Given this list of marker genes Ift70a1 (NCBI Gene Id 78802), Tuba1b, Tuba4a (tubulin, alpha 4A), Dync2i1, Tubb4b, Cluap1, Ift57, Dynlt5, Kifap3, Ift81, Wdr35, Ift25, Dynlrb2, Dync2i2, Ift80, Ift88, Tuba1c, Tubb4a, Dynlt2a3, Dynll1, Tuba3b, Ift172, Ift70b, Tubb6, Ift27, Tuba1a, Ift74, Tubb2b, Dynlt2a2, Ift22, Ttc21b, Kif3c, here is a description of the gene set: part of: Assembly of the 9+0 primary cilium This event has been computationally inferred from an event that has been demonstrated in another species.<p>The inference is based on the homology mapping from PANTHER. Briefly, reactions for which all involved PhysicalEntities (in input, output and catalyst) have a mapped orthologue/paralogue (for complexes at least 75% of components must have a mapping) are inferred to the other species. Reactome Pathway: Intraflagellar transport electronically inferred by orthology from the curated human pathway studied in species Mus musculus